Given this list of marker genes AGPAT3, SIPA1L2, PREX1, MAPK7, TRAK2, SELENOW, POU5F2, ULBP1, ARFGAP2, HNRNPH1, ENTPD7, BNIP2 (BCL2 interacting protein 2), SYF2, WDR27, PRKAG1, CCDC134, FOXO4, ANKRD13D, ARHGAP1, ARHGDIB, NFKBIZ, PPP1R21, GGPS1, INPP5A, E4F1, VAV2, SRGAP2, ZNF592, ZYG11B, PSD4, OTUD5, KAT2B, TSPO, NETO2, ZNF653, APLP2, B3GNT8, SENP7, NR1H2, EGFL8, SAG, LYSMD3, ORAI2, AXIN2, KLHL17, PIK3R3, LIMK2, TNRC6B, ZNF579, FHIP2B, TXNIP, DCLRE1C, PKD1, CCDC88B, TNPO2 (NCBI Gene Id 80048), AP3D1, IDNK, RSF1, SNX25, RNF6 (NCBI Gene Id 6049), TM9SF3, MACO1, TBX6, CASP14, LZTFL1, DNAJC5, NBR1, PLEKHF2, EPHB6, HDHD5, DIP2A, DDX3Y, SETD7, TAOK2, CCM2, KCNA2, PAN2, TP53INP1, BRAF, SDF2 (stromal cell derived factor 2), CTDSP2, TOB1, PHKG2, ZNF354C, EPC2, AMPD1, TRAM1, YIPF4, CYB561D1, PTTG1IP, TAF8, FRYL (NCBI Gene Id 728298), CCNG2, PI4KB, CSRNP2, ATAD2B, ATG9A, DNAJC3, IDS, SMC4, MINDY2, UBALD2, KIF5B, ZNF687, PTPRC, ATG16L1, ARAP2, TCF12, TLE5, EPSTI1, GMEB2, ARHGAP45, PHF12, MAF1, ATP6V1E1, DFFA, IGSF23, TRIM39, ZNF597, ABLIM1, RLF, EP300, MBTPS1, KDM4B, SUPT20H, SLC30A9, ZMYM5, ATXN7, TBCEL (NCBI Gene Id 219899), CFL1, TMOD3, GPBP1, BCL10, USP32, TNFAIP3, SECISBP2L, KIF3B, SEC62, RASAL3, PSTPIP1, SF3B1, CNGA1, GPATCH11, SENP6, TNRC6C, IP6K2, ZNF646, FBXW5, GNA13, MARK3, MDP1, APBB1IP, SIRT7, LBR, PHF1, PPTC7, ZNRF1, SGK1, PBX2, PHF3, S100A13, AFF1, ACADM, KMT2E (lysine methyltransferase 2E (inactive)), MCAM, RABAC1, MLLT10, LYNX1, FAM89B (family with sequence similarity 89 member B), LDB1, TDRP, STRN, ABCC5, CAMK1D (NCBI Gene Id 57118), KDM3B, LATS1, STIM2, SYNJ2BP, MAP1LC3B, FMNL1, N4BP2, HIF1A (NCBI Gene Id 3091), IRGQ, H2BC13 (H2B clustered histone 13), NFAT5, ANXA7, TRIP11, RANBP6, TRIOBP, TMEM50A, RNF38, SBK1, SLK, DLG3, BACH1, RBM5, KDM6B, BRWD3, GPR146, CHD1, here is a description of the gene set: Genes down-regulated in comparison of CD4- CD8- thymocytes versus CD4+ CD8+ thymocytes. Mouse thymocytes can be classified into four major subsets based on expression of CD4 and CD8 co-receptors. CD4-CD8- (double negative, DN) cells become CD4+CD8+ (double positive, DP) cells following productive T cell receptor (TCR) beta chain rearrangement. A small proportion of DP cells are selected through interaction of clonal TCRalpha/beta and MHC self peptide complex expressed on thymic stromal cells. DP cell expressing MHC class I-restricted TCR become CD4-CD8+ cells, which will finally differentiate into cytotoxic T cells, while MHC class II restricted selection generates CD4+CD8- helper lineage T cells. We used microarrays to identify genes important for thymocyte differentiation and lineage determination by profiling gene expression in different thymocyte subsets. studied in species Homo sapiens Human Gene Set: GSE31082_DN_VS_DP_THYMOCYTE_DN from publication Egawa T, Littman DR (PMID 21873191)